The following is a description of a gene set: species: Mus musculus Presynaptic function of Kainate receptors Mouse Gene Set: REACTOME_PRESYNAPTIC_FUNCTION_OF_KAINATE_RECEPTORS, and this is the list of marker genes: Gngt1, Gnb3, Gng4, Gng12 (NCBI Gene Id 72111), Plcb2, Gng10, Gnb4, Plcb3, Gng5, Gng3, Gngt2, Plcb1, Gnb5, Gnb1, Gng13, Gng8, Gng7, Gng11, Grik3, Gng2, Gnb2